Given this list of marker genes WARS1, AKAP7, MAP4K1, RHOH, RIPK2, PIERCE2, APLP1 (amyloid beta precursor like protein 1), SKAP1, C11orf54, TEX2, FBXO31 (F-box protein 31), LY6E, UNC5CL, EXOSC5, CSF2RA, SCAF1, NMB, HINT1, PAK1 (p21 (RAC1) activated kinase 1), SDHAF1, EPB41L2, SMYD3, RBM11, GBP7, TAP2, LMAN1, DCTD, PDE2A, NFKBIE, NAXE, DPP7, TMEM241, TRIM46, SLC2A9, ABHD4, ASAP2, NFKB1, PLEKHM2, BBS12, SLC22A17, ERG28, NCLN, SDR39U1, ST14, KCNK6, PEX11A (NCBI Gene Id 95687), QNG1, SNRPD1, OAZ1, PIGF, NFKBIL1, FLOT2, MVB12A, SLC35D1, SERINC3, SCAPER, VAV2, CACNA1S, TRIM37, KIAA1958, DPY19L4, NUDT2, C11orf86, GALNS, FBXO6, TEKT1, PANX1, FUCA2, MARVELD2, DENND1A, NLRX1, MZT2B, UBE2N, MCM9, BRSK1, INPPL1, AP1S3, SNX33, CFAP91, CAPSL, ANP32B, SLC37A4, SEPTIN9, ZDHHC4, ACAA1, REXO2, METTL15, CREBL2, FBRSL1, LIX1L, MIPOL1, HERPUD2, ZNF703, REEP3, TAX1BP3, TERT, HELB, CHMP1A, SNX13, GNPDA1, AK3, PLRG1, TM4SF5, NDUFV1, MICU3, NR1H2, RAD21, LTA, RCAN1, PARVG, PPM1D, GSR, RAB3GAP2, FAM217B, FSD2, DRC1, ALDOC, MAVS, POGLUT2, VCP, ERN1, GCSH, CD96, TMT1A, SGTA, B9D1, PRIM2, ZMYM1, MIGA1, TDRD7, RCAN3, ASB5, RAD51D, TRIM45, CXCR6, MFSD14A, CD48, KCTD13, NAF1, PDZK1IP1, WEE1, PFN1, TNFSF9, RETSAT, GATA3, STIM2, LONP1, TMEM165, TIMP2, SLAMF1, DECR1, NXPE3, ANXA2, SLC5A6, FBXL17, ZFAND2A, TBC1D2, UBL3, JUND (JunD proto-oncogene, AP-1 transcription factor subunit), HLA-DRB1, POMGNT1, PPM1J, RBM12, ZYX, UBQLN4, UNC93B1, DHCR7, ALDH18A1, CXCL10, KIF20A, ZNF213, RBM38, MEDAG, GABPB1, PHETA2, OBI1, ST8SIA4, ACACA, MAPK9, ICAM1, SLC39A4, KRBA1, ZNF490, METTL26, RBL2, RPS6KC1, FTSJ3, SNRNP27, CHD9, ZCCHC9, HAUS3, SELENOM, MIS12, FDX1, VAV3, RAB37, YIPF1, LITAF, BCL7C, IFIT1B, here is a description of the gene set: studied in species Homo sapiens from publication Wei G, Wei L, Zhu J, Zang C, Hu-Li J, Yao Z, Cui K, Kanno Y, Roh TY, Watford WT, Schones DE, Peng W, Sun HW, Paul WE, O'Shea JJ, Zhao K (PMID 19144320) Multipotential naïve CD4+ T cells differentiate into distinct lineages including T helper 1 (Th1), Th2, Th17, and inducible T regulatory (iTreg) cells. The remarkable diversity of CD4+ T cells begs the question whether the observed changes reflect terminal differentiation with heritable epigenetic modifications or plasticity in T cell responses. We generated genome-wide histone H3 lysine 4 (H3K4) and lysine 27 (H3K27) trimethylation maps in naïve, Th1, Th2, Th17, iTreg, and natural (n)Treg cells. We found that although modifications of signature cytokine genes (Ifng, Il4, and Il17) partially conform to the expectation of lineage commitment, critical transcription factors such as Tbx21 exhibit a broad spectrum of epigenetic states, consistent with our demonstration of T-bet and IFN-gamma induction in nTreg cells. Our data suggest an epigenetic mechanism underlying the specificity and plasticity of effector and regulatory T cells and also provide a framework for understanding complexity of CD4+ T helper cell differentiation. Genes down-regulated in comparison of naive CD4 T cells versus natural regulatory T cell (Treg). Human Gene Set: GSE14308_NAIVE_CD4_TCELL_VS_NATURAL_TREG_DN